The following is a description of a gene set: Genes down-regulated in mice with skin specific knockout of TP53. from publication Martínez-Cruz AB, Santos M, Lara MF, Segrelles C, Ruiz S, Moral M, Lorz C, García-Escudero R, Paramio JM (PMID 18245467) Squamous cell carcinomas (SCC) represent the most aggressive type of nonmelanoma skin cancer. Although little is known about the causal alterations of SCCs, in organ-transplanted patients the E7 and E6 oncogenes of human papillomavirus, targeting the p53- and pRb-dependent pathways, have been widely involved. Here, we report the functional consequences of the simultaneous elimination of Trp53 and retinoblastoma (Rb) genes in epidermis using Cre-loxP system. Loss of p53, but not pRb, produces spontaneous tumor development, indicating that p53 is the predominant tumor suppressor acting in mouse epidermis. Although the simultaneous inactivation of pRb and p53 does not aggravate the phenotype observed in Rb-deficient epidermis in terms of proliferation and/or differentiation, spontaneous SCC development is severely accelerated in doubly deficient mice. The tumors are aggressive and undifferentiated and display a hair follicle origin. Detailed analysis indicates that the acceleration is mediated by premature activation of the epidermal growth factor receptor/Akt pathway, resulting in increased proliferation in normal and dysplastic hair follicles and augmented tumor angiogenesis. The molecular characteristics of this model provide valuable tools to understand epidermal tumor formation and may ultimately contribute to the development of therapies for the treatment of aggressive squamous cancer. species: Mus musculus Human Gene Set: MARTINEZ_TP53_TARGETS_DN, and this is the list of marker genes: PKDREJ, CCND1, MTF2, ACTN3, RAB4A, VAMP8, PADI3, PIGU, CHEK2, KRTAP13-2, MAN2B1, CLK1, PDK4, ABCA2, XPO5, MTA1, VDR, USP18, MT1F, ECRG4, BACH2, FKBP5, IGDCC4, SLC35A2, CERS4, SLC35B1, FRYL, RPS24, ENOX2, EDC4, MKI67, TSPO, PDE3A, SRRM1, PANK1, RAB12, ATF7IP2, DIAPH3, PDS5A, TGS1, MGA, ERRFI1, STX18, POLG, WRAP73, RCC2, INTS6L, PRELP, PINLYP, EGLN3, XIST, KAT7, TC2N, RASL11B, MST1R, CCNL1, RPL37A, PRMT5, FA2H, CDK2AP1, AFF2, HOXA3, AP4S1, KRT23, COPS9 (COP9 signalosome subunit 9), KRT36, RPL34, HHIP, RNASET2, PIP, CELSR2, RAB6A, GRK4, DSTYK, G6PD, PCOLCE, PPIB, DDR1, HOOK2, MIF4GD, LPIN1, LPCAT1, RRAD, KRTAP9-9, SRSF3, INCENP, C1R, DPYSL3, CANX, ENC1 (ectodermal-neural cortex 1), FGF7, SAFB2, EPHX1, CHD4, TUBA4A, RPL3L, PLCB1, FUBP1, CENPA, CCT2, GDPD3, CRTC3, SULT2B1 (NCBI Gene Id 6820), SMO, CWH43, CRYBA4, KRT31, RPL23 (NCBI Gene Id 9349), CTNS, LSR (NCBI Gene Id 54595), TRH, NEO1, SLURP1, PATZ1, C1D, FZD6, KRT82, EFTUD2, LY6G6D, RMND5B (NCBI Gene Id 64777), JUNB (JunB proto-oncogene, AP-1 transcription factor subunit), SLC44A1, FABP4, KRTAP20-1, SCYL1, RHBG, BRD2, ESRP1, TRO, SNCA, HR, PGD, KRTCAP2, ADIPOQ, FADS3, ZMYND11, BAALC (BAALC binder of MAP3K1 and KLF4), BCR, CLEC10A, KRT71, IRX4, TFDP1, UTY (ubiquitously transcribed tetratricopeptide repeat containing, Y-linked), TPR, HACD4, FOXC1, APLP2, WDR12, PLIN4, SPINT1, SCYGR1, NME7, ADGRG1, LSM12, PTGDS, TECR, GPRC5D, DKK2, TP53, RPS6, UAP1, PHB2, ACVR2B, AURKC, PIGB, DAP, SFXN3, H2BC13, HRAS, PTTG1IP, ZFP36, EXTL3, RPS7, KRT81, KIF1C, WDR75, CTNNBIP1, FLNA, KRT79, GGT1, EPRS1, PMFBP1, RASSF3, CCND2, TIMP1, THRAP3, DOP1B, FXYD4, TPO, MAML1, DNAJC3 (DnaJ heat shock protein family (Hsp40) member C3), GSK3B, BACH1, CTSB, CHST1, CPT1A, OVOL1 (NCBI Gene Id 5017), PKIG, CYP2G1P, KRTAP5-2, CLU, GOLGA4, MYBL2, RHOV, SPTBN2, GNMT, SUPT6H, UBQLN4, HOMER2 (NCBI Gene Id 9455), ACAN, MRPL52, POU1F1, STRBP, C22orf39, ATP5IF1, NEUROD4, HSD17B11, RPS18 (ribosomal protein S18), PKD1, KRTAP15-1, RDH11, TCF20, AATF, KRTAP12-2, GJB6, CRIM1, TIMP3, TMED10, PPIH, COL18A1, SLC5A6, XDH, TNRC6A, PTPRF, PARP3, BAMBI, GJB2, MYH1, MBP, CLIP4, KRTAP4-11, DCT, APOE, RNF149, RPL14, RPS8, WRN, RARG, COL6A2, ATF1, FASTKD2, SCMH1, RETNLB, CYP17A1, NFE2L3, FZD7, SMAD1, MYH3, HSPA8, MLLT1, DYNLT1, TCHH, ARL8B, TARDBP, TFAP2B, WFDC21P, SF3A2, NPY, BMERB1, NFIB, FAAP20, PLXNB3, MT1X, KRT25, LDHB, ABCE1, THRA, FBP1, CACFD1, PRSS12 (NCBI Gene Id 8492), ANK3, LAD1 (NCBI Gene Id 3898), LGALS7, RHBDL3, SIAH1, CELF1, PSMC4, RPS17, KRTAP19-3, SHMT1, PSORS1C2, MT4, MARCKSL1, CDH5, MRPL39 (NCBI Gene Id 64977), VN1R17P, EDN3 (endothelin 3), MYH14, CES4A, SNX30, POLR3A, EPHX2, SOX5, ALDH3A1, PAM16, SAP18, KRT35, MBD3L2, RIOK2, KRTAP19-8, CALD1, AMMECR1L, HERC6, GAS1, SLC7A5, CDKN1A, SOX9, AQR, SH3RF1, TNNT1, ATP11A, FGFBP1, NKD2, NUMA1, VIRMA, CIBAR1, SON (SON DNA and RNA binding protein), PLK1, ZDHHC5, DNPH1, EFNB1, PKP2, IMPACT, CTNNAL1, EIF3E, PMEPA1, POLR2A, SHISA2, COL9A3, SSBP2, CAMK2B, KRT83, CDH3, DLX1, SP110, NECTIN2, NDUFA3, PAX6, NHSL1, TMOD2, MYH6, MTREX, CAMKK2, OS9, IFFO2, KRTAP19-5, ATXN7L3B, ITPR3, HMGB1, PABPN1, RBBP4, SNTB2, SF3B2, MSX2, TJP2, MGLL, GSTP1, TLE3, SLC27A4, ECE1, EGR2 (NCBI Gene Id 1959), NPEPL1, PIP5K1C, SLC1A5, PTPN13 (NCBI Gene Id 5783), PPP4R3B, CALR, KRTAP6-1, PLOD2, KRT86, IGFBP2, CEBPG, DDX3Y, RETREG3, KRTAP1-3, ILF3, ATP5PD, PFKFB3, MAP3K5, RIOK3, KRTAP8-1, LEP, CHAC1 (ChaC glutathione specific gamma-glutamylcyclotransferase 1), GRHL1, KMT5A, DUS1L, HOPX, ADAMTS4, KRT33B, MEIS2, IGFBP4, ST14, KRT72, FOXP1, C6orf132, SIVA1, HLA-B, TRIM2, IAPP, RYR1, LTBP2, HUWE1, POLDIP3, CLNS1A, CA6, ZNF280D, CSNK1D, SOX2, PLXNA2, UBE2F, FOXO1, CRYL1, COL11A1, ELOVL6, BICC1, SMAD4, HMGCS1, YPEL1, NHERF2, ZDHHC14, COL1A1, TNMD, FBN2, ARHGEF25, ATP2A2, SLC39A11, BASP1, YIPF4, GLIPR1L2, RPL21, EGFR, SMARCA4, CXXC5, LIG3, FHDC1, PRNP, INTS9, KRTAP4-5, DNAJC17, KRT75, SLC25A30, RPL31, PIGQ, KRT33A, KRT34, MAN2C1, TMEM131L, IDI1, ACSL5 (NCBI Gene Id 51703), POLR2L, CALHM5, TOMM70, NCDN, POM121, PFN2, KRT12, ATP6V0C, ERC1, GCLC, CEBPB, TRBV28, KERA, PPCDC, SFRP2, KRTAP19-1, PLEC, AGFG2, ETHE1, QNG1, TAOK1, NDUFA2, RPS21, CUX1, LASP1, MAP4, ACTRT2, CCDC137, KRT32, HNF4G, HJURP, WWC1, TMCC3, EPAS1, RIMS2, RHOG, APBA3, LAMA5, H2BC5, RPN2, AGPAT1, RBBP8, TOR2A, EFNA3, TG, LCE1A, GALR1, UBL5, SNRPG, ATM, CPSF4, NOTCH1, USP19, MAX, DMD, KDM5B, S100A10, S100A3, CLCN3, CX3CR1, MFAP3, ERO1A, RTRAF, SLC39A14, RBFOX2, GABRP, SCARA3, RBBP6, MRPL33, KLK10, MNDA, MASP1, CAP1, MIS12, MSH4 (NCBI Gene Id 4438), BBIP1, SMARCD2, NAV2, TEX261, TENM2, SLC25A10, ALDH1A3, CRYM, DLX3, UPP1, UBE3A, CSF1R, ELN, MCL1, RTP4, SEPHS2, GNA13 (G protein subunit alpha 13), NDEL1, GSDMA, UNC5B, PCBP2, ZNF574, FHL2, KRT17, LYAR, RPL37, GIP, HACD2, PDAP1, UCP2, PMEL, GTF2B, SLC39A6, MRTFA, SPRR1A, FKBPL, UBC, ZCCHC9, AARS1, PDCD7, LGALS3BP, TENM4, FRMD4B, KRT27, PIWIL2, KRTAP5-4, KRTAP4-1, NDUFA5, EDARADD, HMGA1, S100A14, KRTAP3-1, SREK1, RHOU, ELOVL3 (ELOVL fatty acid elongase 3), WNT5A, KRT85, BRD3, CELF4, ZNF148, MARCKS, NR2F1, NFIA, CER1, LGR5, KRTAP9-4, CD248, HIPK2, RPL27, QKI, MYO10, SCAF11, UBLCP1, SPESP1 (NCBI Gene Id 83599), PTPRE, LMTK2, RPL26, EIF4EBP1, RIPK4, PURB, SDHAF4